Given this list of marker genes HBG2, HBA1, HBB, HBD, HBE1, HBZ (NCBI Gene Id 3050), HBM, HBA2, HP, HBQ1, HBG1, here is a description of the gene set: A protein complex formed by the stable binding of a haptoglobin to hemoglobin. Human Gene Set: GOCC_HAPTOGLOBIN_HEMOGLOBIN_COMPLEX studied in species Homo sapiens